Given this list of marker genes Syt3, Ralgapa1, Nmnat2, Coro1b, Mtch1, Tspan11, Zcchc3, Aph1a (NCBI Gene Id 76226), here is a description of the gene set: from publication Chen Y, Wang X (PMID 31504780) species: Mus musculus Mouse Gene Set: MIR_151_5P Genes predicted to be targets of miRBase v22 microRNA mmu_miR_151_5p in miRDB v6.0 with MirTarget v4 prediction scores > 80 (high confidence targets).